Given this list of marker genes WNT5A, SPEF1 (sperm flagellar 1), ZNRF3, WNT5B, CSNK1E, GPC3, RNF213, PLEKHA4, DAAM2, MLLT3, TIAM1, RSPO3 (NCBI Gene Id 90095), NPHP3, IFT80, SFRP5, SFRP1, MKS1 (NCBI Gene Id 54903), ANKRD6, LBX2, SFRP4, ABL1, DAB2, DACT1, DKK1, CSNK1D, NKD1, here is a description of the gene set: studied in species Homo sapiens Any process that modulates the frequency, rate or extent of non-canonical Wnt signaling pathway. Human Gene Set: GOBP_REGULATION_OF_NON_CANONICAL_WNT_SIGNALING_PATHWAY